Given this list of marker genes FANCF (NCBI Gene Id 2188), CFH, CD46 (NCBI Gene Id 4272), CFI, HELLPAR, here is a description of the gene set: Human Gene Set: HP_PLACENTAL_ABRUPTION studied in species Homo sapiens Separation of the placenta from the uterus wall before delivery. Placental abruption